Given this list of marker genes Cngb1, Sh2b1, Hexim1, Fam241b, Clrn3, Tshz1, Bambi, Arhgef2, Lonrf1, Tbx15, Duxbl1, Nkiras2, Plppr2, Trim24, Elmod3, Rs1, Fam131a, Tnfrsf12a, Zfp385a, Tlr8, Bag3 (NCBI Gene Id 29810), Cdc42bpg, Phf12, Col27a1, Pitpnm3 (NCBI Gene Id 327958), Per1, B4galt2, here is a description of the gene set: studied in species Mus musculus from publication Chen Y, Wang X (PMID 31504780) Mouse Gene Set: MIR_3072_3P Genes predicted to be targets of miRBase v22 microRNA mmu_miR_3072_3p in miRDB v6.0 with MirTarget v4 prediction scores > 80 (high confidence targets).